Given this list of marker genes HMGA1P1 (high mobility group AT-hook 1 pseudogene 1), FAM47DP, TFDP1P2, MAGEB16, PIGFP3, RNA5SP501, FTH1P27, FTHL18P, FTH1P29, PPP4R3C, MIR548F5, MIR4666B, ORC1P1, PAFAH1B2P1, GK-IT1, MAGEB2, H3P43, RDXP3, XK, FTHL17, MAGEB4, CFAP47, VENTXP1, SRSF2P1, TAB3, GK-AS1, MAGEB1, MAGEB18, MAGEB5, GK, DCAF8L1, NFYCP1, H2AL1MP, FTLP2, DMD-AS3, TMEM47, LANCL3, RNU6-894P, MAGEB10, MAGEB3, FTH1P28, PTP4A1P5, RPS15AP40, FAM47C, RNU1-142P, RNU6-641P, TASL, PRRG1 (NCBI Gene Id 5638), RNA5SP500, MOB1AP2, IL1RAPL1, FTH1P19, TAB3-AS1, RANBP1P1, RDXP2, FAM47A, FTH1P14, CKS1BP6, MIR3915, ARX, DCAF8L2, RNU6-1087P, CYBB, TBCAP1, METTL1P1, HMGB1P16, DMD, RN7SL91P, ENSG00000226484, VKORC1P1, NPM1P8, PLCE1P1, MIR6134, TAB3-AS2, SIAH1P1, FMN2P1, MAGEB6B, H2AL1Q, MAGEB6, RPL7P58, AMZ2P3, RPP40P1, FAM47B, NR0B1, here is a description of the gene set: Human Gene Set: chrXp21 studied in species Homo sapiens